The following is a description of a gene set: studied in species Homo sapiens Genes in the cancer module 395. Human Gene Set: MODULE_395, and this is the list of marker genes: TUBA4A, AP1S2, HPCA, TUBB4B, SEC24D, AP3S1, HPCAL1, AP2M1, SEC31A, ARCN1, LRP8, AP2S1, TBCC, AP2A1